Given this list of marker genes Prps1, Prps1l3, Prps1l1, Prps2 (phosphoribosyl pyrophosphate synthetase 2), Prpsap1, Prpsap2, here is a description of the gene set: A protein complex having ribose phosphate diphosphokinase activity. Mouse Gene Set: GOCC_RIBOSE_PHOSPHATE_DIPHOSPHOKINASE_COMPLEX species: Mus musculus